Given this list of marker genes GAS1, TTC5, KDM4B, TGIF1, DENND5A, TCF20, DIS3L2, PIGW, MEG3, PIGY, CDC42, PIGO, PIGB, SLC4A10, IL1RAPL1, MBD5, UNC80, MICU1, NALCN (NCBI Gene Id 93074), HOXB1, PLAA, CHAMP1, GLI2, IQSEC2 (IQ motif and Sec7 domain ArfGEF 2), PRKACB, BAP1, SLC25A46, SHH, PPP2R1A, NRCAM, KDM6A, KMT2D, DCHS1, ZNHIT3, PURA, EEF1A2, PPP1R21, KCNH1, SUFU, FZD2, PREPL, BRAT1, PGAP3, GOLGA2, TGFB3, CDON, SMPD4, DISP1, GPC4, SIX3, NCAPG2, MYL2, FBXO11, CACNA2D1, MSL3, IER3IP1, CRIPTO, FLII, FGFR1, RSPRY1, ESAM, FGF8, ROR2, FBXO28, MEIS2, CNTNAP2, H3-3A, MYOD1, FOXH1, OTUD7A, TMEM237 (transmembrane protein 237), RYR1 (ryanodine receptor 1), RAB11B, DPM1, FOXG1, CHMP1A, PIGN, CSF1R, UFC1, NODAL, TBCK, CLCN3, WDR4, ADAMTSL1, CYFIP2, NSRP1, KCNK9, NEXMIF, ANKRD11, GALNT2, DLK1, STRADA, ATRX, KCNJ6, DLL1, PGAP2, RAPSN, MESD, RTL1, AHDC1, PTCH1, WBP4, DMPK, TAF8, NXN, MED25, ALDH6A1, DDB1, MECP2, ZIC2, PIGL, RNU4-2, RAI1, PIGV, GNAI1, PAX3, PIGT, TMEM147, FAT4, SCN4A, DEAF1, here is a description of the gene set: species: Homo sapiens Human Gene Set: HP_TENTED_UPPER_LIP_VERMILION Tented upper lip vermilion Triangular appearance of the oral aperture with the apex in the midpoint of the upper vermilion and the lower vermilion forming the base.